Given this list of marker genes Park7, Fundc1, Tomm7, Tomm6, Tuba1b, Ubb (ubiquitin B), Pex5 (peroxisomal biogenesis factor 5), Prkn, Dync1li2, Vim, Csnk2b, Map1lc3b, Tubb2b, Rps27a, Ift88, Pgam5, Tubal3, Tomm20, Optn, Ulk1, Tuba1a, Tuba1c, Vdac3, Tuba3b, Atg12, Tomm5, Mterf3, Cetn1, Tomm22 (NCBI Gene Id 223696), Tuba4a, Tubb6, Dynll1, Tubb4b, Ube2n, Tuba8, Nbr1, Vdac1, Sqstm1, Mfn2, Tubb4a, Pink1, Vdac2, Ube2v1, here is a description of the gene set: Reactome Pathway: Selective autophagy species: Mus musculus part of: Macroautophagy electronically inferred by orthology from the curated human pathway This event has been computationally inferred from an event that has been demonstrated in another species.<p>The inference is based on the homology mapping from PANTHER. Briefly, reactions for which all involved PhysicalEntities (in input, output and catalyst) have a mapped orthologue/paralogue (for complexes at least 75% of components must have a mapping) are inferred to the other species.